The following is a description of a gene set: from publication Lake BB, Chen S, Hoshi M, Plongthongkum N, Salamon D, Knoten A, Vijayan A, Venkatesh R, Kim EH, Gao D, Gaut J, Zhang K, Jain S (PMID 31249312) studied in species Homo sapiens Human Gene Set: LAKE_ADULT_KIDNEY_C26_MESANGIAL_CELLS, and this is the list of marker genes: KALRN, COL4A2, PIEZO2, CDC42BPA, TTC28, LHFPL6 (LHFPL tetraspan subfamily member 6), A2M, ROCK1, SEPTIN7, FCHSD2, MEF2C, DLC1, AHNAK, SPAG9, SBF2, B2M, DAPK2, TIMP3, DUSP1, IL1RAPL1 (interleukin 1 receptor accessory protein like 1), PTPRM, POSTN, NBEAL1, AKAP9, PSD3, PDGFRB, ZBTB16, PTPRG, PCDH9, ARID5B, PDE7B, UNC5C, SPARC, NFKBIA, GATA3, MTSS1, MEIS2 (NCBI Gene Id 56908), APBB2, ADGRL2, EMCN, SSBP2, FOSB, TBC1D1, LINC-PINT, CAMK2D, PHTF2, PRKCA, ZFP36L1, TACC1, PDE3A, HSPA1B, RAPGEF2, SAMD12, WNK1, SH3D19, EPAS1, ARGLU1, NKTR, GAS2, MAML3, INPP4B, PTEN, ENG, SYNE1, ADGRF5, HERC1, HSPH1, COL4A1, RBMS1, NR2F2-AS1 (NR2F2 antisense RNA 1), ETS1, NRG3, MYH9, FOS, RORA, MAP3K5, ANKRD11, USP53, C7, AGTR1, JUN, TBL1X, CACNA2D1, UACA, ITPR1, PPP1R12A, DOCK8, LPP, CBLB, PLPP1, PLCL1, FTX, TSC22D1, ZEB2, PLXDC2, ROBO1, MGP, MYO1D, ELL2, IL18R1, RASAL2, IL6ST, LAMA2, RAPGEF5, PTPRD, UBC, TMSB4X, ANKRD12, RBMS3, GPX3, TEX41, ITGA11, MAML2, SLC38A2, FBXL7, AKAP12, PALLD, NCOA1, TMTC1, TNS3, PDS5B, IGFBP5, DAAM2, ITGA1, TCF4, LMO7, MEIS1, EPB41L2, IGFBP7, TNS1 (tensin 1), UBR3, SLCO3A1, NBEA, COL25A1, NEAT1, ITGA8, DGKH (NCBI Gene Id 8524), DPYD, DST, TOP1, EBF1, HSP90AA1, CRIM1, TJP1, NEK7, HLA-E, DNAJB1, UTRN, PIP5K1B, EXT1, NR4A1, FRMD4A, ROCK2, PRR16, CPM, ALDOB, DLEU2, MYO1E, PRKG1, EGR1, BMPR2 (bone morphogenetic protein receptor type 2), HSPB1, EPS8, STARD13, AKT3, SPOCK1, CALD1, HIPK2, SPTBN1, ACTN4, RAPH1, PPARG, COL12A1, ASCC3, HSPA1A, DOCK4, AQP1